Given this list of marker genes Tlr4, Hbb-bt, Apoa1, Apob, Mafk, Ly96, Pgrmc2, Xpo1, here is a description of the gene set: part of: Cellular responses to stress This event has been computationally inferred from an event that has been demonstrated in another species.<p>The inference is based on the homology mapping from PANTHER. Briefly, reactions for which all involved PhysicalEntities (in input, output and catalyst) have a mapped orthologue/paralogue (for complexes at least 75% of components must have a mapping) are inferred to the other species. species: Mus musculus electronically inferred by orthology from the curated human pathway Reactome Pathway: Heme signaling